Given this list of marker genes FOLH1, TYMS, SLC25A32, AASDHPPT, SLC46A1 (solute carrier family 46 member 1), ATIC, SLC19A1, SHMT2, ALDH1L1, FPGS, GCH1, MTR, MTHFD1 (NCBI Gene Id 4522), MTRR, SHMT1, MTHFD2L, MTHFR, ALDH1L2, DHFRP1, DHFR2, FOLR1, MTHFS, MTHFD2, FTCD, GGH, DHFR, MTHFD1L, PM20D2, here is a description of the gene set: Human Gene Set: GOBP_FOLIC_ACID_CONTAINING_COMPOUND_METABOLIC_PROCESS The chemical reactions and pathways involving a folic acid-containing compound, i.e. any of a group of heterocyclic compounds based on the pteroic acid skeleton conjugated with one or more L-glutamic acid or L-glutamate units. studied in species Homo sapiens